Given this list of marker genes Cacnb1, Lck, Ptger3, Ptgs1, Chrm3, Notch1, Myh7b, Glrx3, Cmya5, Hand2, Casq2, Map2k1, Arg2, Rock2 (Rho-associated coiled-coil containing protein kinase 2), Adra1a, Gdf1, Ryr1, Yy1, Pde5a, Kcnma1, Tnnt3, Chga, Igfbp5, Gja5, Ppp3ca (protein phosphatase 3, catalytic subunit, alpha isoform), Cald1, Gata4, Dmd, Irag1, Pde9a, Tnnt2, Cacng1, Nol3, Grk2, F2r, Nppa, Prkag3, Igf1, Atp1a2, Tnfrsf1b, Chrm2, Akap1, Mtpn, G6pdx, Ptger4, Srf, Shc1, Npy2r, Fbxo32, Fdps, Ghrl, Adora2b, Pparg, Lmna, Adk, Slc25a4, Dmpk, Selenon, Tbxa2r, Gper1, Jup, Nmu, Bmp10, Eno1, Nkx2-5, Tnni1, Parp2, Cacnb2, Smtn, Dag1, Edn2, Tnni3k, Rnf207, Lmcd1, Gsn, Tnnt1, Grcc10, Adra1b, Ndufs4, Tacr2, Ttn, Rem1, Adrb2, Pkp2, Trim63, Edn1, Ctdp1, Tnnc1, Rgs4, Ppara, Ep300, Atp2b4, Abcc8, Tead1, Tomm70a, Myh7, Twf1, Atp2a2, Prkd1, Foxp1, Casq1, Chrnb4, Akap9, Prok2, Adra2a, Tnnc2, Eno1b, Nr4a1, Ormdl3, Scn10a, Mtor, Smad4, Mlip, Trpm4, Gsk3a, Cdk9, Bin1, Rhoa, Rgs2, Pi16, Ptafr, Sri, Cacna1s, Calm2, Fkbp1b (FK506 binding protein 1b), Neurog1, Adra2b, Camk2d, Sod1, Agrn, Sphk1, Zfp418, Cacna1c, Adcy10, Kcna1, Nfatc3, Gata5, Pin1, Trip10 (NCBI Gene Id 106628), Calcrl, Sirt1, Myl3, Nfatc1, Jarid2, Atp2a1, Ucn, Hrc, Adrb1, Pde4d, Tmem38a, Ptk2, Adra2c, Pawr, Gucy1a1, Abat, Npnt, Mef2c, G6pd2, Scn4a, Myocd, Mtmr4, Stc1, Htr7, Oga, Flt1, Mylk2, Stub1, Mstn, Prkca, Edn3, Rangrf, Rock1, Oxtr, Acacb (NCBI Gene Id 97267), Tacr1, Dlg1, Hamp2, Actn3, Itga2, Camk2g, Gtf2ird2, Ada, Gtf2ird1, Ccn4, Chrna3, Ctnna3, Slc8a3, Dsc2, P2rx1, Parp1, Tnfrsf1a, Srl, Gsk3b, Tnni3, Tmem38b, Nr4a3, Smad3, Ccn2, Fxyd1 (FXYD domain-containing ion transport regulator 1), Sln, Ddx39b, Aif1, Mef2a, P2rx4, Dock4, Ryr2, Oxt, Adora1, Kcnn4, Trpv4, Ece1, Dbn1, Prkg1, Pin1rt1, Dsp, Tifab, Pln, Anxa6, Mymk, Slc9a1, Slc8a1, Sgca, Fgf13, Akap6, Tacr3, Atp1a1, Trpc3, Arhgap42 (Rho GTPase activating protein 42), Rbm10, Kbtbd13, Kit, Dsg2, Ptgs2, Klf4, Cav1, Spx, Foxo3, Hdac4, Hsp90aa1, Cav3, Pak1, Atp2b1, Dock5, Hamp, Nos3, Zc3h12a, Errfi1, Cttn, Scn5a, Rps6kb1, Foxo1, Calm1, Agt, Atp1b1, Cacna1h, Smad7, Setd3, Kcnj2, Sumo1, Zdhhc21, Strit1, Ehd3, Becn1, Ghsr, Nr3c1, Myog, Calca, Ank2, Hcn4, Kcnq1, Nppc, Calm3, Ace2, here is a description of the gene set: Any process that modulates the frequency, rate or extent of a muscle system process, a multicellular organismal process carried out by any of the organs or tissues in a muscle system. species: Mus musculus Mouse Gene Set: GOBP_REGULATION_OF_MUSCLE_SYSTEM_PROCESS